Given this list of marker genes Aicda, Cdadc1, Upp1, Dctd, Upp2, Cda, Pycr3, here is a description of the gene set: Mouse Gene Set: GOBP_PYRIMIDINE_RIBONUCLEOSIDE_METABOLIC_PROCESS species: Mus musculus The chemical reactions and pathways involving any ribonucleoside, a nucleoside in which pyrimidine base is linked to a ribose (beta-D-ribofuranose) molecule.